Given this list of marker genes C1QBP, SERPING1, PLAUR, KRT1, F12, KNG1, KLKB1, A2M, HRG, here is a description of the gene set: species: Homo sapiens part of: FXIIa activates plasma kallikrein-kinin system Activated factor XIIa and plasma kallikrein coordinate inflammatory signaling pathways, complement activation, coagulation, and fibrinolysis. This system is tightly regulated by several proteins, including plasma protease C1 inhibitor (C1INH, encoded by the SERPING1 gene), alpha-2-macroglobulin (encoded by the A2M gene), and heparin-binding glycoprotein (HRG), which prevent overactivation of contact activation system and plasma kallikrein-kinin system and protect against pathological thrombotic and inflammatory conditions (Pixley RA et al., 1985; Harpel PC et al., 1985; MacQuarrie JL et al., 2011). C1INH and alpha-2-macroglobulin are the major plasma protease inhibitors of plasma kallikrein accounting for 42 and 48% inhibition, respectively (Schapira M et al., 1981), although their relative contributions vary among studies (Schapira M et al., 1981; Harpel et al., 1985). C1INH (SERPING1) is the predominant inhibitor of FXIIa, accounting for 92% plasma FXIIa inhibition (Pixley RA et al., 1985). Reactome Pathway: Regulation of FXIIa and plasma kallikrein activity